The following is a description of a gene set: studied in species Mus musculus Mouse Gene Set: MIR_3544_3P from publication Chen Y, Wang X (PMID 31504780) Genes predicted to be targets of miRBase v22 microRNA mmu_miR_3544_3p in miRDB v6.0 with MirTarget v4 prediction scores > 80 (high confidence targets)., and this is the list of marker genes: Ikzf4, Sh3glb1, Pptc7, Zbtb43, Nudt10, Sgo1, Tbx15, Zfp738, Spata6l, Pisd, Ifi27l2a, Ift81, Gm14391, Kif11, Polr1e, Wdtc1, Mical3, Ccnj, Mr1, Nkain2, Shisa2, Gpr62, Meis1, Gm6710, Ddx6, Kcnb1, Samd14, Gm14296, Zfp867, Ptpn1, Dcp1a, Tpbpa, Tulp4, Garin5b, Scn4b, Mycbp, Cdk6, Cadm1, Fads3, 2210418O10Rik, Edrf1, Cmc2, Capn5, Dcaf10, Pitpnm2, Eif4e, Cd40, Camsap1, Mrgprg, Bcl2l2, Dcp2, Tmcc2, Zfp1009, Rubcn, Tmx4, Fgd5, Prpf39, Fam114a2, Rab3d, Gm14322, Cd200r2, Adcyap1r1, Inip, Chrna9, Kif14, Uroc1, Hoxd4, Nek9, Bach2 (NCBI Gene Id 319905), Cacybp, Zfp970, Vav2, Med1, Gale, Bok